Given this list of marker genes NEDD4, WWP2, ANO6 (anoctamin 6), MIR21, KCNE3, DLG1, NPPA, KCNE5, NEDD4L, KCNH2, WNK4, KCNIP2, here is a description of the gene set: Human Gene Set: GOBP_REGULATION_OF_POTASSIUM_ION_EXPORT_ACROSS_PLASMA_MEMBRANE Any process that modulates the frequency, rate or extent of potassium ion export across the plasma membrane. species: Homo sapiens